The following is a description of a gene set: Mouse Gene Set: GOBP_AMP_SALVAGE species: Mus musculus The chemical reactions and pathways resulting in the formation of adenosine monophosphate (AMP) from derivatives of it (either adenine, ADP or adenosine 3',5'-bisphosphate) without de novo synthesis., and this is the list of marker genes: Pnp, Aprt, Hprt1, Adss2, Ada, Adsl, Adk, Adss1 (adenylosuccinate synthase 1, NCBI Gene Id 11565)